The following is a description of a gene set: part of: Ribosome-associated quality control Non-stop mRNAs (mRNAs that lack a stop codon) result in ribosomal stalls proximal to the 3' end of the mRNA, which are resolved by a distinct pathway. In this case, a complex comprising PELO, a paralog of the ribosome release factor eRF1, and HBS1L:GTP, a paralog of the ribosome release factor eRF3:GTP, binds the stalled ribosome near the subunit interface and the mRNA entry site. PELO:HBS1L preferentially acts on ribosomes that are bound to mRNAs that have fewer than 12 nucleotides extending 3' of the ribosomal P site.<br>HBS1L hydrolyzes GTP and dissociates from PELO and the ribosome, exposing a site on PELO to which ABCE1 binds. ABCE1 then hydrolyzes ATP to cause a conformational change that splits the ribosome into 40S and 60S subunits. ABCE1 and possibly the mRNA remain bound to the 40S ribosomal subunit, while the peptidyl-tRNA remains bound to the 60S ribosomal subunit as in the ASCC-mediated rescue pathway. Reactome Pathway: PELO:HBS1L and ABCE1 dissociate a ribosome on a non-stop mRNA species: Homo sapiens, and this is the list of marker genes: RPL13, RPL7 (ribosomal protein L7), RPL21, RPL4, RPS7, RPLP2, RPL37, RPL12, RPL36AL, RPL11, RPS24, RPL10A, RPL29, RPS17, UBA52 (NCBI Gene Id 7311), RPLP0, RPL3, RPL22L1, RPL39L (NCBI Gene Id 116832), RPL26L1, RPS15, RPL30, RPS2, RPS20, RPL9, RPL17, RPL5, 5.8S rRNA, RPL26, 28S rRNA, RPSA, RPL34, RPL18A (NCBI Gene Id 6142), RPS18, RPL19, RPL18, RPL39, RPL36A, RPS28, RPL32, RPS5, RPL28, RPL22, RPS27A, RPL24, RPL37A, RPL38, FAU, RPS21, RPL6 (ribosomal protein L6), RPL35A, RPL8, RPS4X, RPS29, RPL15, RPS25, RPLP1, RPL7A, RPS11, RPS14, RPL31, RPL35, RPL10L, 18S rRNA, RPL23A, RPS16, RPS4Y1, RPS6, RPL13A, RPL27, RPS10, RPS13, RPS12, RPS15A, RPS9, RPS3A, RPL41 (NCBI Gene Id 6171), RPS4Y2, RPS8, RPS27, RPS3, ABCE1 (NCBI Gene Id 6059), RPS26, RPS19, RPS27L, RPL10, PELO, RPL23, HBS1L, RPL36, RPL3L, RPS23, RPL27A, RPL14, 5S rRNA